The following is a description of a gene set: Human Gene Set: TCCCRNNRTGC_UNKNOWN studied in species Homo sapiens Genes having at least one occurrence of the highly conserved motif M39 TCCCRNNRTGC in the regions spanning 4 kb centered on their transcription starting sites. The motif does not match any known transcription factor binding site. from publication Xie X, Lu J, Kulbokas EJ, Golub TR, Mootha V, Lindblad-Toh K, Lander ES, Kellis M (PMID 15735639) Comprehensive identification of all functional elements encoded in the human genome is a fundamental need in biomedical research. Here, we present a comparative analysis of the human, mouse, rat and dog genomes to create a systematic catalogue of common regulatory motifs in promoters and 3' untranslated regions (3' UTRs). The promoter analysis yields 174 candidate motifs, including most previously known transcription-factor binding sites and 105 new motifs. The 3'-UTR analysis yields 106 motifs likely to be involved in post-transcriptional regulation. Nearly one-half are associated with microRNAs (miRNAs), leading to the discovery of many new miRNA genes and their likely target genes. Our results suggest that previous estimates of the number of human miRNA genes were low, and that miRNAs regulate at least 20% of human genes. The overall results provide a systematic view of gene regulation in the human, which will be refined as additional mammalian genomes become available., and this is the list of marker genes: PES1, PUM1, TRIR, BET1, MYL6B, PLK1, TCTA, R3HDM1, CCDC28A, IFT70A, PRMT5, CLHC1, NEK2, GSPT1, TRAPPC13, UFSP2, SMPD3, FBRS, BDH2, KBTBD7, EXOC4, RPP30, POFUT1, ENTREP3, C6orf62, CYB5R1, SEL1L, SNX16, ZNF189, ELOC, CCP110, TSC22D3, DCUN1D2, CERT1, UBL3, OTUD5, HSPH1, PCM1, ANKS3, XPOT (NCBI Gene Id 11260), NUTF2, CDK16, CNOT4, MTF2, DNAL1, CEP97, ARHGAP44, DLG4, TUBGCP3, PRPF19, UBAC1, CERS3, HAUS6, CSRNP3, SON (SON DNA and RNA binding protein), MON1A, C1GALT1C1, SNX11, RAB1A, CASC3, YTHDC1, BUB1B, SMIM11, IFT70B, XK, TRABD, RRS1, PTCD3, CSRNP2, RASSF6, DQX1, CEP290, ORC4, FAM133A, PA2G4, TMEM74, BIN2, ZNF428, PNRC2, PNPLA6, KLK9, RDH10, EDEM3, EIF2B4, TRAF3IP1, NOS3, USP16, SPC25, TIMP4, IPO7, GART, MBP, DCAKD, WTAP, FCSK, RAD50, SMG1, SCAMP4, ACADVL, TTC1, KIF11, PRCC, MRPL24, VCL, C8orf76, INVS, RHOA (ras homolog family member A), LUC7L3, FANCB, BRMS1, KRR1, CREBZF, RBM6, LIN37, ZCCHC8, ZNF354C, COX4I1, CENPO, RPL30, CCDC150, CHD4, SRSF9, LZTR1, PHACTR3, ASXL1 (NCBI Gene Id 23393), IFRD2, RHOQ, SNX17, TFAP4, SRSF1, BRS3, MORF4L1, CSNK2A1, VAPA, INSRR, TMEM33, ZNF212, MBD6 (methyl-CpG binding domain protein 6), KHSRP, IRF2BP1, KBTBD6, NSD1, DNAAF8, MAG, TBC1D23, STARD13, ADO, POLR1A, NMT1, CHCHD3, PMM2, EYA4, HSPB9, FYCO1, VKORC1, AKIRIN2, ZSWIM9, PLAGL2, POLK, POLR1G, RPS27A, TMCO3, WFIKKN2, KAT2A, RB1CC1, INTS9, EMC8, CCDC25, TPGS2, HMBOX1, NFATC2IP, SLC4A2, FAM120C, ABCB6, MED11, EIF5A, NUDT13, FNBP1L, MRPL50, CEND1, TMEM115, HDAC8, TRIM23, RPL7, TMEM186, MOSPD2, WASHC3, STMN1, ISL1 (ISL LIM homeobox 1), USP15, PPP1R8, CKAP4, CDK5, GDE1, ZIC5, GSK3A, KPNB1 (karyopherin subunit beta 1), AZIN1, ADSS2, TLE4, ABRAXAS2, CCDC92, LIG1, PSMD11, CLINT1, CALCOCO1, ZNF664, KMT2D, GRIN2B, FOXRED2, NDC1, ASXL2, BSN (bassoon presynaptic cytomatrix protein), ADAT3, NAP1L3, UBALD1